Given this list of marker genes Kcnj11, Hectd1, Pkdcc (protein kinase domain containing, cytoplasmic), Rangrf, Lypla1, Atp2c1, Sqstm1, Cnpy4, Pgrmc1, Numb, Pid1, Lrrc15, Pik3r2, Sfn, Vti1b, Tmed2, Csnk2a1, Wnk1, Cln3, Dlg1, Lgals3, Atp2b4, Myo5a, Cdh1, Pdpk1, Ppp1r9b, Wnk3, Epha3, Zdhhc7, Stac3, Akap5, Trem2, Arf6, Prkci, Ar, Ptpn9 (protein tyrosine phosphatase, non-receptor type 9), Ins2, Camk2d, Lrp1, Dab2, Csk, Cnst, Stac, Stx3, Clip3, Vamp4, Ppfia1, Epha2, Arhgef16, Actb, Itga3, Camk2b, Pkp1, Wnt3a, Ap2m1, Akt1, Pls1, Rack1, Ldlrap1, Stx4a, Tmbim1, Actr3, Camk2a, Ins1, Tgfb1 (NCBI Gene Id 21803), Csrp3, Cib1, Zdhhc5, Epm2a, Sirt6, Egfr, Sorbs1, Tnf, Rab11fip2, Stac2, Mrap2, Prnp, Nrxn1, Picalm, Tmem59, Rer1, Rab11a, Lypd1, Appl1, Camk2g, Bcl2l1, Gper1, Stx7, Vil1, Grip1, Agr2, Pik3r1, Acsl3, Ephb2, Gripap1, Itgb1, Ramp3, Dpp6, Stx8, Mmp14, Kif5b, Vps4a, Commd1, Arhgap44, Rhoq, Dpp10, Ngdn, Ppp2r5a, Nhlrc1 (NCBI Gene Id 105193), Abi3, Myo5b, Vamp8, Ezr, Sptbn1 (spectrin beta, non-erythrocytic 1), Lyplal1 (lysophospholipase-like 1), Rhog, Mrap, Cdk5, Wnk4, Nkd2, Zdhhc2, Cltc, here is a description of the gene set: Any process that modulates the frequency, rate or extent of protein localization to plasma membrane. studied in species Mus musculus Mouse Gene Set: GOBP_REGULATION_OF_PROTEIN_LOCALIZATION_TO_PLASMA_MEMBRANE